The following is a description of a gene set: species: Homo sapiens Genes predicted to be targets of miRBase v22 microRNA hsa-miR-6774-5p in miRDB v6.0 with MirTarget v4 prediction scores > 80 (high confidence targets). from publication Chen Y, Wang X (PMID 31504780) Human Gene Set: MIR6774_5P, and this is the list of marker genes: METTL8, MTCL2, NAA15, TAF4B, FAM120C, UBE2D3, MPPE1, CCDC6, BTBD1, NXF3, KLHL32, TOP2A, CMTM6, SKI, CCL20, CD69, PAFAH1B1, PLXDC2, GAB3, MTSS1, SEPTIN9, PIGZ, EPHB4, DSC2, PTPRM, PLD1, LRRC8A, PRX, SIDT2, COG7, PRDM16 (PR/SET domain 16), PYGB, RUNX2, KAT14, PML, COL8A2, NID1, ESYT1, MAGEA5P, APEX1, ADRA1A, IFNAR1, KIFC1, GLUL, BCCIP, PM20D1, KMT2A, RIT2, ENSG00000266560, HSPA5, SLC11A2, CYC1, RPS6KA3